Given this list of marker genes Rab3gap1, Dtnbp1, Kmo, Gabbr1, Avp, Stxbp1, P2rx7, Nr3c1, Syt4, Cck, Adora2a, Dpysl2, Grin2b, Avpr1a, Ntsr1, here is a description of the gene set: studied in species Mus musculus Mouse Gene Set: GOBP_POSITIVE_REGULATION_OF_GLUTAMATE_SECRETION Any process that activates or increases the frequency, rate or extent of the controlled release of glutamate.